Given this list of marker genes PF4V1, RNASE6, MUC7, KLK3, SEMG1, XCL2, HTN1, DEFB4A, VIP, H2BC4, CCL8, PGC, H2BC6, SPAG11B, CXCL3, CCL4L2, CXCL14, H2BC12, CXCL5, NPY, H2BC8, DEFB127, DEFA4, TSLP, DEFA1B, CCL15, CXCL13, GAPDH, CXCL9, CCL26, PGLYRP4, GALP, CCL16, CX3CL1, BPI (NCBI Gene Id 671), ROMO1, CXCL1, CCL14, CCL28, CCL24, TOR2A, CALCA, F2 (NCBI Gene Id 14061), REG1B, RPS19, PF4, DCD, CCL21, S100A12, CAMP, CCL4, FAM3A, NPPB, RNASE7, H2BC10, H2BC12L, BPIFA1, DEFB103A, ANG, HAMP, FAU, DEFB1, RPL30, CCL1, PPBP, DEFB130A, KRT6A, S100A9, RNASE3, CCL11 (NCBI Gene Id 6356), LEAP2, CCL2, TAC1, CCL18, DEFA5, CXCL11, CXCL6, REG3G, ADM, H2BC21, EVPL, CCL25, CXCL10, IL17F, CCL3L3, CCL20, SPINK5, DEFA6, LGALS4, ELANE, HMGN2, DEFB126, CCL7, H2BC7, PLA2G1B, S100A7, HTN3, PGLYRP1, CXCL12, CCL3, CCL27, DEFA1, XCL1, CCL23, KLK5, DEFB131A, CCL17, CXCL2, B2M, DEFB103B, PGLYRP3, POMC, CCL13, LGALS3, CXCL8, CCL19, KNG1, DEFA3, DEFB118, H2BC11, HRG, GNLY, DMBT1, CCL22, IL17A, APP, LTF, REG1A, RPL39, MMP7, KLK7, CCL5, REG3A, NTS, here is a description of the gene set: species: Homo sapiens An immune response against microbes mediated by anti-microbial peptides in body fluid. Human Gene Set: GOBP_ANTIMICROBIAL_HUMORAL_IMMUNE_RESPONSE_MEDIATED_BY_ANTIMICROBIAL_PEPTIDE